Given this list of marker genes PRIM1, IFT140, DPH2, KPTN, HSD17B4, COL25A1 (collagen type XXV alpha 1 chain), ARCN1, ALG14, FBN1, KCNJ5, IL11RA, THUMPD1, ASXL3, SCARF2, KIF15, NFIX, RFX7, CNTN1, IFT43, ATP6V0A2, SCN4A, PEX19, DPH1, IL6ST, IFT122, IDS, FBN2, KCNJ2, TBC1D7, AGO2, EXTL3, TWIST1, RNU4-2, ERGIC1, SOX6, GLI3, RYR1, KRAS, SCYL2 (SCY1 like pseudokinase 2), TRAIP, here is a description of the gene set: Human Gene Set: HP_SCAPHOCEPHALY Scaphocephaly is a subtype of dolichocephaly where the anterior and posterior aspects of the cranial vault are pointed (boat-shaped). Scaphocephaly is caused by a precocious fusion of sagittal suture without other associated synostosis. Scaphocephaly studied in species Homo sapiens